The following is a description of a gene set: studied in species Homo sapiens Human Gene Set: GOCC_SCHAFFER_COLLATERAL_CA1_SYNAPSE A synapse between the Schaffer collateral axon of a CA3 pyramidal cell and a CA1 pyramidal cell., and this is the list of marker genes: DTNBP1, ARHGDIA, PLG, PRKAR1B, ATG5, UBE2I, ABR, LRFN2, KCNK2, WNT7A, CAPZB, PCDH8, STX3, GHSR, INA, SYNGR1, PTN, PTPRS, CTNNB1, GIPC1, MAPK9, CASK, ADRB1, PFN2, ACTG1, FBXL20, NETO1, CACNG2, ADORA2B, NEFL, GABRB1, SYN1, LRP8, CDH11, DVL1, SYN2, AKAP12, ACTB, PPP3CA, APBA1, CACNG3, P2RX3, SLC30A1, STX1A, GHRL, TUBB2B, STAT3, SHANK1, BSN, EEA1, PRKCI, DCC, ITPR1, NTNG1, SLC16A7, ADCY1, LRRTM2, ADCY8, LRRC4C, PPFIA1, PAFAH1B1, STX4, SYP, RALA, EPHA7, LRRC4 (leucine rich repeat containing 4), HIP1, EPHA4, NOTCH1, WNT5A, GRM5 (glutamate metabotropic receptor 5), PLAT, PRSS12, BCR, CHRM1, PPP3R1, TNR, APBA2, ROCK1, GRM1, NEFH, SLC1A1, FYN, PLPPR4, RHOB, RAB11A, BAIAP2, GABBR1, SNX27, GSG1L, CPLX1, PTPRD, EFNB2, RAP2A (RAP2A, member of RAS oncogene family), CALM3, IQSEC2, NTNG2, ITGB1, ADORA3